Given this list of marker genes MYMX, EIF4A3, SATB2, SNRPB, BUB1, PIGA, COL9A2, KCNK4, TGDS, SLC35B2, KIF15, ZFX, PGM1, SLC10A7 (NCBI Gene Id 84068), TBX1, FLNA, MAP3K7, DGCR8, COL11A1, CAPRIN1, COG1, DGCR2, RBM10, GRB10, MYMK, ESS2, AMER1, SCUBE3, DGCR6, BMP2, YY1, ANKRD17, COL2A1, NEDD4L, COL11A2, here is a description of the gene set: Pierre-Robin sequence Human Gene Set: HP_PIERRE_ROBIN_SEQUENCE species: Homo sapiens Pierre Robin malformation is a sequence of developmental malformations characterized by micrognathia (mandibular hypoplasia), glossoptosis and cleft palate.